The following is a description of a gene set: Genes predicted to be targets of miRBase v22 microRNA mmu_miR_1904 in miRDB v6.0 with MirTarget v4 prediction scores > 80 (high confidence targets). Mouse Gene Set: MIR_1904 from publication Chen Y, Wang X (PMID 31504780) studied in species Mus musculus, and this is the list of marker genes: Dennd1b, Adgrl3, Pik3ca, Kcnq5, Kat6b, Dusp2, Thumpd3, Tut4, Phactr2, Ice2, Dclre1c, Scn8a, Osgep, Zfp811, Nr2e3, 2900092C05Rik (RIKEN cDNA 2900092C05 gene), Zbtb33, Gnal, Stxbp1 (NCBI Gene Id 98927), Fut9, Sprr3, Rictor, Sprr2a2, Srgap2, Nkiras1, Slc2a13, Caskin1, Prps1l3, Vcpip1, Cldn34c1, Sulf1, Arap2, Nsun6, Zfp518b, Tbx5, Atrn, C1ql2, Hspa9, Nexmif, Slc13a1, Fhl1 (four and a half LIM domains 1), Col19a1, Slc5a3, Slc37a3, Fndc7, Chka, Hcn1, Rin2, Colec12, Zcchc4 (NCBI Gene Id 78796), Steap2, Slc48a1, Slc9a6, Or4n5, Prb1a, Slfn5, Tox, Pbp2, Septin9, 1110032F04Rik, Aak1, Slitrk4, Nfix, Bnip3, Bmt2, Upk1b, Sprr2a1, Mxi1, Ahsa2, Cep97, Kdm3a, Wdfy3, Cd160, St8sia4, Dkk2, Tspyl1, Tmem59, Slc4a4, Fbxo32, Robo2, Pwwp3b (PWWP domain containing 3B), Gpr180, Esco2, Ogt, Hcar2, Spta1, Zcchc2, Map2, Ark2c, Slc10a2, Plxna4, P2ry10, Phip, Mis12, Mdh1, Sgsm1, Lysmd3, Pcsk6, Pygo2, Sp1, Sertad2, Grem2, Nyap2, Kbtbd4, Fcho2, Arl13b, Naa15, 6430550D23Rik, Kcng3, Fbxo22 (F-box protein 22), Slc30a4, Apoh, Mtcl2, Ubr3, Rbm45, Ehbp1, Man1a2, Dach2, Ms4a6d, Cxxc4, Samd7, Dcx, Icos, Rmnd5a, Mapk8, Usp32, Elovl6, Irs1, Ttc17, Hpcal4, Bex2, Elovl4, Mpzl1, Hand2 (heart and neural crest derivatives expressed 2), Bicd1, Tmem72, Phf20 (NCBI Gene Id 228829), 1700025G04Rik, Pik3c2a